Given this list of marker genes AGRN, SDC3, GPC1, EXT1, SDC1, EXT2, SDC2 (syndecan 2), GPC4, SDC4, GPC5, HSPG2, GPC6, GPC3, GPC2, here is a description of the gene set: studied in species Homo sapiens Defective EXT2 causes exostoses 2 Human Gene Set: REACTOME_DEFECTIVE_EXT2_CAUSES_EXOSTOSES_2